Given this list of marker genes Alox15, here is a description of the gene set: studied in species Mus musculus part of: Biosynthesis of DPAn-3 SPMs Reactome Pathway: Biosynthesis of DPAn-3-derived protectins and resolvins This event has been computationally inferred from an event that has been demonstrated in another species.<p>The inference is based on the homology mapping from PANTHER. Briefly, reactions for which all involved PhysicalEntities (in input, output and catalyst) have a mapped orthologue/paralogue (for complexes at least 75% of components must have a mapping) are inferred to the other species. electronically inferred by orthology from the curated human pathway